The following is a description of a gene set: Binding to glycogen. species: Mus musculus Mouse Gene Set: GOMF_GLYCOGEN_BINDING, and this is the list of marker genes: Ppp1r3a, Ppp1r3d, Ppp1r3b, Ppp1r3e, Ppp1r3f, Ppp1r3c (NCBI Gene Id 53891), Ppp1r3g, Epm2a, Stbd1